The following is a description of a gene set: studied in species Mus musculus Mouse Gene Set: GOBP_SUBSTRATE_ADHESION_DEPENDENT_CELL_SPREADING The morphogenetic process that results in flattening of a cell as a consequence of its adhesion to a substrate., and this is the list of marker genes: Src, Calr, Lamc1, Bves, Parvg, Ilk, Rhoa, Itgb7, Dock5, Nrp1, Lamb3 (NCBI Gene Id 16780), Spry4, Itgb1bp1, St6gal1, Tek, Fer, Unc13d, Crk, Ephb3, Parvb, Rac1, Rcc2, P4hb, Sfrp1, S100a10, Dab2, Lama5, Tyro3, Vamp3, Radil, Dmtn (NCBI Gene Id 13829), Coro1c (NCBI Gene Id 23790), Ntn4, Micall2, Bcar1, Cspg5, Nedd9, Crkl, Carmil1, Cib1, Antxr1, Arpc2, Srcin1, Postn, Lamb1, Braf, Fermt3, Myadm, Mertk, Efna5, Cdc42, Itgav, Apoa1, Fn1, Enpp2, Fzd7, Akip1, Fermt2, Abl1, Cass4, Tacstd2, Axl, Pxn, Ptk2, Itgb3, C1qbp, Myoc, Rab1a, Triobp, Meltf, Itga8, Tesk1, Efna1, Fbln1, Rreb1, Parva, Ap1ar, Fndc3b, Fzd4, Lims2, Prex1, Kank1, Lims1, Dbn1, Epha1, Dnm2, Mdk, Lpxn, Megf9, Itga4, Flna, Olfm4, Pdpn, Has2, Pkp2, Actn4, Kif14, Lamb2, Peak1, Dock1, Rac3